Given this list of marker genes SMPD1, NEU1 (neuraminidase 1), CSF2RB, LAMB2, ASAH1, PIK3CG, LCAT, NPC1, NPC2, SC5D, APOE, CSF2RA, GLB1, LIPA, HLA-DRB1, here is a description of the gene set: studied in species Homo sapiens The presence of foam cells, a type of macrophage that localizes to fatty deposits on blood vessel walls, where they ingest low-density lipoproteins and become laden with lipids, giving them a foamy appearance. Human Gene Set: HP_FOAM_CELLS Foam cells